Given this list of marker genes KRT6B, TERT, NF2, TRAF7, SMARCE1, PIK3CA, SMO, SUFU, AKT1, KRT6A, PDGFB, KRT17, SMARCB1 (NCBI Gene Id 6598), BAP1, KRT16, here is a description of the gene set: Pain in the ear can be a consequence of otologic disease (primary or otogenic otalgia), or can arise from pathologic processes and structures other than the ear (secondary or referred otalgia). studied in species Homo sapiens Ear pain Human Gene Set: HP_EAR_PAIN